Given this list of marker genes H1f5, H1f0, H1f8, Ncaph2, Ncapd3, H3f3b, Dffb, Acin1, Baz1b, Ncapd2, Akap8l, Ern2, H1f9, Ncaph, Ccnb1, Prm2, H1f10, Atf6b, H1f4, Gper1, H1f7, Smarca5, Nusap1, Ncapg2, Hmga2, Prm3, H3f3a, Mcph1, Kdm4a, Akap8, Cdca5, Smc2, Cdk1, Smc4, Phf13, Smc5, H1f6, H1f2, H1f3, Ncapg, Fbxo30, Top2a (topoisomerase (DNA) II alpha), H1f1, Prm1, Chmp1a, here is a description of the gene set: Mouse Gene Set: GOBP_CHROMOSOME_CONDENSATION The progressive compaction of dispersed interphase chromatin into threadlike chromosomes prior to mitotic or meiotic nuclear division, or during apoptosis, in eukaryotic cells. studied in species Mus musculus